The following is a description of a gene set: Hemoglobin F (HbF) contains two globin alpha chains and two globin gamma chains. It is the main form of hemoglobin in the fetus during the last seven months of intrauterine development and in the half year of postnatal life. In adults it normally makes up less than one percent of all hemoglobin. This term refers to an increase in HbF above this limit. In beta thalassemia major, it may represent over 90 percent of all hemoglobin, and in beta thalassemia minor it may make up between 0.5 to 4 percent. Human Gene Set: HP_PERSISTENCE_OF_HEMOGLOBIN_F studied in species Homo sapiens Persistence of hemoglobin F, and this is the list of marker genes: ZBTB7A, RPL18 (NCBI Gene Id 6141), TSR2, RPS26, RPS7, RPS19, RPL35 (NCBI Gene Id 92393), RPL26, HBB, SBDS, HBG1, RPL9, SLC30A7, MDM4, RPS29, RPS20, BCL11A (BCL11 transcription factor A), HBG2, RPS10, RPL27, RPS27 (ribosomal protein S27), RPS28, RPL31, RPL15, RPL35A, HEATR3, KLF1, ADA2, SRP54, RPS24, RPL8, RPS17, RPS15A, RPL5, GATA1, DNAJC21, RPL11